Given this list of marker genes Kif20a, Tnfaip8, Ccnd1 (cyclin D1), Incenp, Reep1, Kif2c, Slc4a7 (NCBI Gene Id 218756), Rpl13a, Marcksl1, Rbm3, Bub1, Top2a, Atf3, Trim59, Ccnb2, Cdc20, Mcm7, Id2, Cxcl14, 2700099C18Rik, H2az1, Cuedc2, Chl1, Coro1c, Ppp1r14b, Nhp2, Foxd3, Tnc, Tmx2, Fignl1, Cks2, Hmga2, Ect2, Cip2a, Cdk1, Basp1, Smc2, Spred2, Lsm2, Ezh2, Cks1b, Cadm1, Uhrf1, Specc1, Mcm5, Epha5, Tcf19, Iqgap3, Hdac2, Plk1, Marcks, Csrp2 (cysteine and glycine-rich protein 2), Cdkn1c, Mki67, Usp1, Erdr1, Mcam (melanoma cell adhesion molecule), Rfc5, Nusap1, Hnrnpa2b1, Slc22a23, Nav2 (NCBI Gene Id 78286), Cd44, Birc5, H2ax (H2A.X variant histone), Ccna2, Kif23, Ednrb, Mad2l1, Mcm4, Kpna2, Rbl1, Sox2, Aurka, Lin9 (NCBI Gene Id 98218), Gm4739, D17H6S56E-5, Cxcr4, Sh3gl3, Bzw2, Plk4, P2rx4, Cotl1, Pou3f1, Cdc7 (cell division cycle 7), Tenm3, Gm4870, Rrm1, Tubb6, Cdca8, Dnajc9, Rad51, Rpa3, Kif11, Rrm2, Pclaf, Ncaph, Ccl2, Plekho1, Prc1, Ezr, Kif22, Ube2t, Ets1, Pde8a, Tnfrsf21, Klf10, Lmnb1, Pspc1, Nt5dc2, Col18a1, Jpt1, Trim17, here is a description of the gene set: studied in species Mus musculus from publication Le N, Nagarajan R, Wang JY, Araki T, Schmidt RE, Milbrandt J (PMID 15695336) Genes up-regulated in P14 nerves of transgenic mice having hypomorhic (reduced function) allele of EGR2. Egr2 is a transcription factor required for peripheral nerve myelination in rodents, and mutations in Egr2 are associated with congenital hypomyelinating neuropathy (CHN) in humans. To further study its role in myelination, we generated mice harboring a hypomorphic Egr2 allele (Egr2Lo) that survive for up to 3 weeks postnatally, a period of active myelination in rodents. These Egr2Lo/Lo mice provided the opportunity to study the molecular effects of Egr2 deficiency on Schwann cell biology, an analysis that was not possible previously, because of the perinatal lethality of Egr2-null mice. Egr2Lo/Lo mice phenocopy CHN, as evidenced by the severe hypomyelination and increased numbers of proliferating Schwann cells of the peripheral nerves. Comparison of sciatic nerve gene expression profiles during development and after crush injury with those of Egr2Lo/Lo Schwann cells revealed that they are developmentally arrested, with down-regulation of myelination-related genes and up-regulation of genes associated with immature and promyelinating Schwann cells. One of the abnormally elevated genes in Egr2Lo/Lo Schwann cells, Sox2, encodes a transcription factor that is crucial for maintenance of neural stem cell pluripotency. Wild-type Schwann cells infected with Sox2 adenovirus or lentivirus inhibited expression of myelination-associated genes (e.g., myelin protein zero; Mpz), and failed to myelinate axons in vitro, but had an enhanced proliferative response to beta-neuregulin. The characterization of a mouse model of CHN has provided insight into Schwann cell differentiation and allowed the identification of Sox2 as a negative regulator of myelination. Mouse Gene Set: LE_EGR2_TARGETS_UP